The following is a description of a gene set: Human bone marrow mesenchymal stem cells (hMSCs) give rise to adipocytes in response to adipogenic hormones. An in-house cDNA microarray representing genes was employed to characterize the modulation of genes involved in this process. A total of genes showed temporal gene expression changes during adipogenesis, including genes encoding transcriptional regulators and signaling molecules. Semi-quantitative RT-PCR analyses confirmed differential expression at the transcriptional level of several genes identified by cDNA microarray screening. Cluster analysis of the genes regulated during the late phase (from day 7 to day 14) of hMSC adipogenesis indicated that these changes are well correlated with data previously reported for murine preadipocytes. However, during the early phase (day 1-day 5), the modulations of genes differed from those reported for the preadipocytes. These data provide novel information on the molecular mechanisms required for lineage commitment and maturation accompanying adipogenesis of hMSC. Human Gene Set: NAKAMURA_ADIPOGENESIS_EARLY_DN from publication Nakamura T, Shiojima S, Hirai Y, Iwama T, Tsuruzoe N, Hirasawa A, Katsuma S, Tsujimoto G (PMID 12646203) Genes down-regulated in mesenchymal stem cells during early phase of adipogenesis, defined as days 1 to 5 of culturing with adipogenic hormones. studied in species Homo sapiens, and this is the list of marker genes: RGS4, MYH11, SERPINE2, LOX, TNFRSF11B, TMEM47, CALD1, TIMP3, HCK, ZNF133, SRPK2, COL15A1, POSTN, CCN1, EPOR, VCAM1, EDIL3, ITGAV, LRP3, GDF15, RAI14, GLIPR1, PDE6D, ITGA3, HAPLN1, ABI3BP, PRSS23, THBS2, COL9A3, ACTG2, STK38L, TPM1, IER2, SERPINE1, NT5E